The following is a description of a gene set: part of: Peroxisomal lipid metabolism studied in species Homo sapiens Reactome Pathway: Beta-oxidation of very long chain fatty acids Linear fatty acids containing more than 18 carbons are broken down by beta-oxidation in peroxisomes to yield acetyl-CoA and medium chain-length fatty acyl CoA's such as octanoyl-CoA., and this is the list of marker genes: ECI2, ABCD1, SLC27A2, ACOT4, DECR2, ACAA1, ACOT8, HSD17B4, EHHADH, MLYCD (malonyl-CoA decarboxylase), ACOX1